The following is a description of a gene set: Genes up-regulated in lupus susceptibility locus Sle2c1 B lymphocytes from: peritoneal cavity versus spleen. from publication Xu Z, Potula HH, Vallurupalli A, Perry D, Baker H, Croker BP, Dozmorov I, Morel L (PMID 21543644) Human Gene Set: GSE23114_PERITONEAL_CAVITY_B1A_BCELL_VS_SPLEEN_BCELL_IN_SLE2C1_MOUSE_UP species: Homo sapiens Sle2c1 is an NZM2410-derived lupus susceptibility locus that induces an expansion of the B1a cell compartment. B1a cells have a repertoire enriched for autoreactivity, and an expansion of this B cell subset occurs in several mouse models of lupus. Here we showed that expression of Sle2c1 enhances NZB cellular phenotypes that have been associated with autoimmune pathogenesis. A combination of genetic mapping and candidate gene analysis presents Cdkn2c, a gene encoding for cyclin kinase inhibitor p18INK4c (p18), as the top candidate gene for inducing the Slec2c1 associated expansion of B1a cells. A novel SNP in the Cdkn2c promoter is associated with a significantly reduced Cdkn2c expression in the splenic B cells and B1a cells from Sle2c1-carrying mice, which leads to defective G1 cell cycle arrest in splenic B cells and increased proliferation of Pc B1a cells. As cell cycle is differentially regulated in B1a and B2 cells, these results suggest that Cdkn2c play a critical role in B1a cell self renewal, and that its impaired expression leads to an accumulation of these cells with high autoreactive potential., and this is the list of marker genes: INS, COL4A2, IRF2BP1, SERPINF1, GATAD1, CD247 (NCBI Gene Id 919), PLA2G4C, MT2A, FADS3, MUC1, CXCR4, SIPA1, TAOK3, PAPSS2, TPBG, FAM3A, ATG13, AFDN, DOCK2 (NCBI Gene Id 1794), ARID4B, ID1, ITSN1, BIN1, DGKA, H2BC10, PCNX1, SEC31B, MICA, TYRP1, CTSO, DDIT3, USP19, CADPS, LINC00302, ARHGEF18, SGK1, MFGE8, P2RY10, IKBKG, NUMA1, SMAGP, CASQ2, RASGRP2, MRNIP, MMP16, DLGAP4, VSNL1, PPARD, CXCL12, ALDH6A1, TRAM2, C2orf72, OXT, RHBDL1, HHEX, PLXNB3, ARHGAP45, DNM3, ZKSCAN5, PADI2, ERICH1, H3C10, SIT1, CLN3, LTB4R, RHOB, TBX19, IDH2, CIZ1, HDAC6, CTSW (NCBI Gene Id 8849), TENM1, ADA, VPS11 (NCBI Gene Id 55976), RECQL5, IRF3, CTNNBIP1, JUND, RGS1, IFITM3, ENDOU, CLDN9, FCGRT, OASL, ASIC3, SETD1B, PLCD1, ESR1, EYA2, TLR1, SELPLG, ZBTB25, SARDH, CIT, KCNA5, HSD3B2, KRT20 (keratin 20), UPK3A, PNOC, TBC1D9, ALDH2, RNF139, GAD2, PENK, KAT7, GPSM3, SLC2A3, PPT2, SIRPA, SMR3B, P2RX5, SORBS3, CDC25B, TANC2, ICAM3, STARD5, SORL1, NCKIPSD, S100A13, MCC, PRKCE, PCBP3, B3GALT4, DMPK, MYO6, CORO1A, OPTN, DUSP8, AURKC, PIM1, LPCAT4, MYL2, TRAF3IP2, ARHGAP4, TLE5, CLDN18, NBEAL2, ARHGEF11, LITAF, CECR7, ZFP36L2, GDPD5, PYGM, TNFRSF13B, MAP4K2, STARD3, TNK2, TMSB10, CD300C, SUN2, PIK3IP1, HMGN3, LINC01565 (long intergenic non-protein coding RNA 1565), GAB2, UTRN, ADD3, AQP5, AXIN1, PIAS3, AMT, RALYL, PCDH7, UBA7, H1-10, AIF1, MYO9B, TRADD (NCBI Gene Id 8717), VAMP1, ZMYM3, PPP2R5D, CCDC69, THRA, ITGA6, MCF2L, TPX2, ERG, HMGN2, WWOX, UBE2C, PRKACG, RBM38, ITGB2, TRANK1, FGB, INSL4, RAB32, CHD2, DLGAP1, DNAJB1, PHYH, SNAP91, IL11RA, DGCR2, CDX2, CPEB3, IFITM1, MTSS1, OCRL, ALOX5, KDM2A